The following is a description of a gene set: Human Gene Set: PUJANA_BREAST_CANCER_WITH_BRCA1_MUTATED_DN The XPRSS-Int network genes down-regulated in breast tumors from patients with germline mutations in BRCA1 compared to those with the wild type allele. from publication Pujana MA, Han JD, Starita LM, Stevens KN, Tewari M, Ahn JS, Rennert G, Moreno V, Kirchhoff T, Gold B, Assmann V, Elshamy WM, Rual JF, Levine D, Rozek LS, Gelman RS, Gunsalus KC, Greenberg RA, Sobhian B, Bertin N, Venkatesan K, Ayivi-Guedehoussou N, Solé X, Hernández P, Lázaro C, Nathanson KL, Weber BL, Cusick ME, Hill DE, Offit K, Livingston DM, Gruber SB, Parvin JD, Vidal M (PMID 17922014) species: Homo sapiens Many cancer-associated genes remain to be identified to clarify the underlying molecular mechanisms of cancer susceptibility and progression. Better understanding is also required of how mutations in cancer genes affect their products in the context of complex cellular networks. Here we have used a network modeling strategy to identify genes potentially associated with higher risk of breast cancer. Starting with four known genes encoding tumor suppressors of breast cancer, we combined gene expression profiling with functional genomic and proteomic (or 'omic') data from various species to generate a network containing genes linked by 866 potential functional associations. This network shows higher connectivity than expected by chance, suggesting that its components function in biologically related pathways. One of the components of the network is HMMR, encoding a centrosome subunit, for which we demonstrate previously unknown functional associations with the breast cancer-associated gene BRCA1. Two case-control studies of incident breast cancer indicate that the HMMR locus is associated with higher risk of breast cancer in humans. Our network modeling strategy should be useful for the discovery of additional cancer-associated genes., and this is the list of marker genes: PAXIP1, CD47, NEMP1, DDX39B, BUB3, TOP1, ZNF330, TBCA, SSBP2